Given this list of marker genes LMNA (NCBI Gene Id 7816), HMGCR, FLNC, PRDM16, ZMPSTE24 (zinc metallopeptidase STE24), ALPK3, ADAMTS19, here is a description of the gene set: studied in species Homo sapiens Abnormal function of the left ventricule during left ventricular relaxation and filling. Left ventricular diastolic dysfunction Human Gene Set: HP_LEFT_VENTRICULAR_DIASTOLIC_DYSFUNCTION